The following is a description of a gene set: species: Homo sapiens Human Gene Set: GOCC_COPI_COATED_VESICLE_MEMBRANE The lipid bilayer surrounding a COPI-coated vesicle., and this is the list of marker genes: DIPK2A, COPZ1, COPB2, KDELR1, TMED2, SCYL1, COPG2, KDELR2, COPB1 (NCBI Gene Id 51664), TMED3, TMEM199, COPA, COPE, TMED7 (NCBI Gene Id 51014), COPZ2, COPG1, KDELR3, ARCN1